The following is a description of a gene set: Any process that stops, prevents or reduces the frequency, rate or extent of hepatocyte proliferation. species: Mus musculus Mouse Gene Set: GOBP_NEGATIVE_REGULATION_OF_HEPATOCYTE_PROLIFERATION, and this is the list of marker genes: Smo, Ceacam2, Cdkn2a (cyclin dependent kinase inhibitor 2A), Cpb2, Lims1, Ceacam1, Lims2